Given this list of marker genes TRH-GTG1-1, TRV-CAC1-1, TRA-AGC1-1, TRA-TGC1-1, TRM-CAT1-1, TRA-CGC1-1, TRI-TAT1-1, TRD-GTC1-1, TRG-CCC1-1, TRE-TTC1-1, TRK-TTT3-1, TRP-AGG1-1, TRG-GCC1-1, TRK-TTT1-1, TRQ-CTG1-1, TRL-CAG1, TRS-GCT1-1, DICER1, ANG, TRE-CTC1-1, TRR-CCG1-1, TRV-AAC1-1, TRP-TGG1-1, ELAC2, TRS-CGA1-1, TRL-TAG1-1, TRV-TAC1-1, TRR-ACG1-1, here is a description of the gene set: Reactome Pathway: tRNA-derived small RNA (tsRNA or tRNA-related fragment, tRF) biogenesis species: Homo sapiens Defined fragments of tRNAs, termed tRNA‑derived small RNAs (tsRNAs), have been observed in particular cell types and in response to biological conditions such as exposure to sex hormone or stresses such as hypoxia, starvation, oxidative stress, and virus infection. Rather than being the random products of tRNA degradation, tsRNAs appear to be the specific products of ribonucleases. Two categories of tRNA‑derived small RNAs (tsRNAs) have been described: (1) longer (31‑40nt) tsRNAs known as tRNA halves or stress‑induced tsRNAs (tiRNAs) that are produced by single cleavage of tRNAs within or near the anticodon and (2) shorter (15‑30 nt) tsRNAs termed tRNA-related fragments (tRFs) that result from cleavage closer to the 5' or 3' end of the tRNA. tRF-3s are derived from the 3' region of the tRNA, approximately the region from the T loop to the 3' terminus. tRF-5s are derived from the 5' region of the tRNA, approximately the region from the D loop to the 5' terminus. tRF2‑type tRFs (also called internal tRFs) are derived from the central region of the tRNA, approximately the region between the D loop and the T loop and containing the anticodon. tRF-1s, also known as Type II tRFs or 3’U tRFs, are the 3' trailers of particular tRNAs that persist after processing.<br>In most cases the enzymes responsible for the cleavages are not yet known, however several ribonucleases involved in cleavage of tRNA have been identified: the secreted and endocytosed ribonuclease A family members angiogenin (ANG) and RNase 1; the interferon-induced ribonucleases RNase L, Schlafen 11 (SLFN11) and Schlafen13 (SLFN13 or RNase S13); the cytosolic ribonuclease III‑like (double strand RNA‑specific) enzyme DICER1; and the RNA processing enzyme ELAC2. ANG is secreted, binds receptors on cell membranes, is endocytosed, and translocates to the nucleus. ANG cleaves within the anticodon loop to produce tRNA halves and the cleavage is thought to occur while ANG is transiently located in the cytosol. Cleavage by ANG is observed in response to cellular stresses such as starvation. However, ANG knockout cells continue to produce stress-induced tRNA halves, suggesting that other enzymes are also involved in producing the halves. Similar to ANG as an RNase A member, the secreted endoribonuclease RNase 1 cleaves tRNAs at the anticodon loop in the extracellular space.<br> Interferon-induced RNases can also cleave tRNAs. RNase L is responsive to double stranded RNAs and cleaves at the tRNA anticodon loop. Schlafen family members SLFN11 and SLFN13 can also cleave tRNAs.<br>DICER1 cleaves double‑stranded regions of tRNAs near the 5' terminus or 3' terminus to produce short tRFs. The mechanism that dissociates the double‑stranded products of DICER1 to yield single‑stranded tRFs may be the same as that for miRNAs, but this has not yet been demonstrated. Furthermore, the bulk of the short tRFs is still detected in DICER1-null cells, suggesting other unknown factors are involved in their biogenesis. ELAC2 in the cytosol cleaves the 3' trailers of precursors of tRNA Ser TGA, tRNA Ser GTC, and tRNA Asp GTC, and tRNA Asp GTC. The trailers (also called tRF-1s) then persist in the cytosol. part of: Gene Silencing by RNA